Given this list of marker genes TENT5B, ETV4, PIM2, MYBL2, CBR3, SOX15, TFCP2L1, DPPA5, LNCPRESS1 (NCBI Gene Id 101927721), DPPA4, POU5F1 (POU class 5 homeobox 1), FRAT2, TEAD4, DND1, USP28, ZNF727, UPP1, DPPA3, TFAP2C, NANOG, NLRP7, SUSD2, VENTX, UTF1, L1TD1, AEN, SLC25A16, VSIG10, PHC1, ZNF296, RAB15, ZYG11A, ZFP42, here is a description of the gene set: Adult male germ cell tumors (GCTs) comprise distinct groups: seminomas and nonseminomas, which include pluripotent embryonal carcinomas as well as other histologic subtypes exhibiting various stages of differentiation. Almost all GCTs show 12p gain, but the target genes have not been clearly defined. To identify 12p target genes, we examined Affymetrix (Santa Clara, CA) U133A+B microarray ( approximately 83% coverage of 12p genes) expression profiles of 17 seminomas, 84 nonseminoma GCTs, and 5 normal testis samples. Seventy-three genes on 12p were significantly overexpressed, including GLUT3 and REA (overexpressed in all GCTs) and CCND2 and FLJ22028 (overexpressed in all GCTs, except choriocarcinomas). We characterized a 200-kb gene cluster at 12p13.31 that exhibited coordinated overexpression in embryonal carcinomas and seminomas, which included the known stem cell genes NANOG, STELLA, and GDF3 and two previously uncharacterized genes. A search for other coordinately regulated genomic clusters of stem cell genes did not reveal any genomic regions similar to that at 12p13.31. Comparison of embryonal carcinoma with seminomas revealed relative overexpression of several stem cell-associated genes in embryonal carcinoma, including several core stemness genes (EBAF, TDGF1, and SOX2) and several downstream targets of WNT, NODAL, and FGF signaling (FGF4, NODAL, and ZFP42). Our results indicate that 12p gain is a functionally relevant change leading to activation of proliferation and reestablishment/maintenance of stem cell function through activation of key stem cell genes. Furthermore, the differential expression of core stem cell genes may explain the differences in pluripotency between embryonal carcinomas and seminomas. Genes whose expression pattern in adult male germ cell tumors (GCT) correlates with POU5F1. studied in species Homo sapiens from publication Korkola JE, Houldsworth J, Chadalavada RS, Olshen AB, Dobrzynski D, Reuter VE, Bosl GJ, Chaganti RS (PMID 16424014) Human Gene Set: KORKOLA_CORRELATED_WITH_POU5F1